The following is a description of a gene set: species: Mus musculus from publication Chen Y, Wang X (PMID 31504780) Mouse Gene Set: MIR_7213_5P Genes predicted to be targets of miRBase v22 microRNA mmu_miR_7213_5p in miRDB v6.0 with MirTarget v4 prediction scores > 80 (high confidence targets)., and this is the list of marker genes: Coro2a, Gpr17, Sh3gl2, Kcns1, Fxyd7, Il10ra, Celsr3, Fbxo41, H6pd, Gpr3, Fryl, Cma1, Zfp628, Lilrb4b, Cbln3, Plec, Kctd12, Crip3, Mip, Tppp3, Supt7l, Nelfcd, Frmd5, Fbxl20, Lsm10, Amer3, Pgam5, Creb3l1, Tnfrsf19, Syne3, Bltp2, Mov10 (NCBI Gene Id 97060), Slc16a2, Ganab, Gabpa, Ark2n, Dner, Prkn, Prr5l, Slc25a31, Slc24a2, Kif26b, Rarg, Smg6, Spsb2, Rbm14, Slx1b, Prr29, Hmgxb4, Aldh6a1